Given this list of marker genes Bcat2 (branched chain aminotransferase 2, mitochondrial), Acat1, Bckdk, Acadsb, Hsd17b10, here is a description of the gene set: studied in species Mus musculus The chemical reactions and pathways resulting in the breakdown of isoleucine, (2R*,3R*)-2-amino-3-methylpentanoic acid. Mouse Gene Set: GOBP_ISOLEUCINE_CATABOLIC_PROCESS